Given this list of marker genes CACNG4, CNIH3, CACNG8, CACNG5, PRRT1, CACNG7, CNIH2, CACNG3, MINK1, SHISA7, CACNG2, here is a description of the gene set: Human Gene Set: GOBP_REGULATION_OF_AMPA_RECEPTOR_ACTIVITY species: Homo sapiens Any process that modulates the frequency, rate or extent of AMPA selective glutamate receptor activity.